Given this list of marker genes FGR, APOB, PPP2CA, PPP2R5A, PECAM1, PPP2R5E, PPP2R5B, LRP8, PPP2R5D, PPP2CB, MAPK14, PPP2R1A, PPP2R1B, PPP2R5C, PTPN6, PLA2G4A, PTPN11, here is a description of the gene set: Human Gene Set: REACTOME_PLATELET_SENSITIZATION_BY_LDL species: Homo sapiens Platelet sensitization by LDL